Given this list of marker genes RAB20, RAB7A, CREG1, SLC9A7, PPT1, TMEM199 (transmembrane protein 199), DMXL2, LAMP1, RNASEK, SLC9A8, SLC11A1, CA2, ATP6V1H, TCIRG1, CLN6, TMEM9, CLN3, ATP6V0A1, CLIC4, SLC12A5, CLCN3, CCDC115, ATP6AP1, ATP6V0B, ATP6V0A4, GPR89B, SLAMF8, BCL2, SLC4A7, UBE3A, ATP6AP2 (NCBI Gene Id 95880), ATP6V0E2, CA7, CLN5, RAB39A, ATP6V0C, ATP6V0D1, ATP6V1B2, ATP6V0A2, ATP6V0E1, LAMP2, AVPR1A, AQP11, ATP6V1F, AVP (arginine vasopressin), ATP6V1A, TPCN2, RAB38, DMXL1, TMEM106B, GPR89A, GRN, ATP6V1B1, ATP6V1D, ATP6V0D2 (NCBI Gene Id 245972), FASLG, SNAPIN, here is a description of the gene set: species: Homo sapiens Human Gene Set: GOBP_INTRACELLULAR_PH_REDUCTION Any process that reduces the internal pH of a cell, measured by the concentration of the hydrogen ion.